Given this list of marker genes Ccno, Sp5, Myo1f (myosin IF), Slc4a7, Cenpm, Tmem253, Nphs1, Cfap144, Nexmif, Nanos3, Trim67, Zc3h13 (NCBI Gene Id 97937), Cpsf4l, Tex19.2, Retsat, Arl4a, Tet1, Gnai1, Gstt2, Crocc2, Trmt1, St3gal6, Tmem54, Cep97, Lmntd2, Dcxr, Psors1c2, Calca, Lefty1, Crlf1, Lefty2, Fzd10, Pramel13, Cercam, 2310022B05Rik, Ccnt2, Cep295, Flywch2 (NCBI Gene Id 77133), Mup6, Man2b1, Rnaseh2c, 2410137M14Rik, Epdr1, Homer2, Trh, Sprr2a3, Nt5e, Has2, Cdx2, Mmp2, Fst, Gabarapl1, AU015836, Csnk2a1-ps3, Sall3, Notch4, Rbp7, Dpp4, Mlxipl (NCBI Gene Id 58805), Snx30, Csn3, Ddx6, Nodal, here is a description of the gene set: The positive transcription elongation factor b (P-TEFb) is essential for the elongation of transcription and cotranscriptional processing by RNA polymerase II. In mammals, it contains predominantly the C-type cyclin cyclin T1 (CycT1) or CycT2 and cyclin-dependent kinase 9 (Cdk9). To determine if these cyclins have redundant functions or affect distinct sets of genes, we genetically inactivated the CycT2 gene (Ccnt2) using the beta-galactosidase-neomycin gene (beta-geo) gene trap technology in the mouse. Visualizing beta-galactosidase during mouse embryogenesis revealed that CycT2 is expressed abundantly during embryogenesis and throughout the organism in the adult. This finding was reflected in the expression of CycT2 in all adult tissues and organs. However, despite numerous matings of heterozygous mice, we observed no CycT2(-/-) embryos, pups, or adult mice. This early lethality could have resulted from decreased expression of critical genes, which were revealed by short interfering RNAs against CycT2 in embryonic stem cells. Thus, CycT1 and CycT2 are not redundant, and these different P-TEFb complexes regulate subsets of distinct genes that are important for embryonic development. Mouse Gene Set: KOHOUTEK_CCNT2_TARGETS from publication Kohoutek J, Li Q, Blazek D, Luo Z, Jiang H, Peterlin BM (PMID 19364821) Genes down-regulated in E14 ES (embryonic stem) cells upon knockdown of CYCT2 by RNAi. studied in species Mus musculus